The following is a description of a gene set: CD25+ regulatory T cells develop in the thymus (nTregs), but may also be generated in the periphery upon stimulation of naive CD4 T cells under appropriate conditions (iTregs). The mechanisms that regulate the generation of peripheral iTregs are largely unknown. We used microarrays to gain insights into the molecular program of extrathymic Treg development. studied in species Homo sapiens Genes down-regulated in comparison of CD25+ regulatory T cell (Treg) treated with IL4 at day 3 versus CD25- T cells incubated with IL4 at day 3. Human Gene Set: GSE24634_TREG_VS_TCONV_POST_DAY3_IL4_CONVERSION_DN from publication Prots I, Skapenko A, Lipsky PE, Schulze-Koops H (PMID 21347372), and this is the list of marker genes: TCEAL4, CYRIA, SNX4, SDC2, GCA, RNF130, ARHGAP10, MAP3K5, ITGB2, LAIR1, PTEN, LGALS1, DPY19L4, TRAPPC12, PLA2G7, COX5B, ANXA2, MCTP1, DYSF, ATOX1, TFEC, UST, RIT1, SNX6, AGPAT4, VPS35L, COMT, HMGCL, HLA-DMA, DUSP3, FCGR2A, CD74, ARRB1, SERINC3, RHOBTB1, ADCY9, CDKN1A, HLA-DMB, TMT1A, APPL2, SKAP2, BLCAP (BLCAP apoptosis inducing factor), P2RY13, TMEM9B, ALOX15B, HLA-DQB1, HSD17B11, CAT, MGLL, BAZ2B, SEMA4A, ATP6V1D, IL18, CYB5R1, DPEP2, TMEM176B, BID (NCBI Gene Id 637), FNDC3A, CALHM2, IFI44, RIN2, MYO7A, SLAMF7, ACP5, MEGF9, ARMH3, HCK, TCIRG1, RNASE1, COX7B (cytochrome c oxidase subunit 7B), COPA, ATP6V0B, PLEK, CD86, ST3GAL5, PMFBP1, TGM2, PFDN5, COPS7A, TTC17, SERPINB8, LAMP1, NAGK, HLA-DRB6, SEPTIN10, NAGA, GLA, PLXND1, MNDA, MPV17, SNX17, NRP1, CHMP2A, LMO2, TENT5A, MMD, NINJ1, PLIN3, RAB38, BMP2K, IL10, SYK, TMCC1, HEXA, TMEM176A, NR1H3, ERO1B, GPX1, FADS1, TRAM2, PDE6D, CMKLR1, ABCA1, ATRN (attractin), C1QA, DSE, NPL, MANBA, CALML4, EPB41L3, CTSC, SLC15A3, KLF11, RAP2B, SERINC5, IL7R, C1orf54, CTSZ, GPR137B, PARP8, CD33, CH25H, CDA, ENG, CRYBG3, CREBL2, SLC22A18, CSF2RA, VPS11, CEBPD, KCTD12, TIMP1, CTSO, CLEC2B, KCNS3, HEXB, EMC3, GBP1, CREG1, CTSB, TM6SF1, TBC1D2, VPS8, ASAH1, TCEAL1, DNASE1L1, CD36, IL10RB, DAB2, JAG1, PLPP3, PXDC1, CARD9, LY96, C1QB, OSBPL1A, ABCC3, TNFSF13, C2CD2, MKNK1, GBA1LP, MOB1A, RNASET2 (NCBI Gene Id 8635), CCL18, PLOD3, DNAJB9, PPT1, TLR1, BACH1, AOC1, ZNF211, SNX27, LGALS3, CCL2, IGFBP7, IFNGR2, SASH1, ITM2B, EHD4, STOM, PSAP, ARHGAP22, ATP6V1C1 (ATPase H+ transporting V1 subunit C1), SLC11A1, SLC38A6, P2RX4, NAGPA, ADIPOR1, GUSBP14, TDRD7